The following is a description of a gene set: from publication Ramirez K, Chandler KJ, Spaulding C, Zandi S, Sigvardsson M, Graves BJ, Kee BL (PMID 22608498) Genes down-regulated in hematopoietic stem cells versus CD4 T cells. Expression profiling of Rag2-deficient Ets1++ and Rag2-deficient Ets1-- mature NK cells and WT bone marrow progenitors, WT T cells, and WT Pro B cells studied in species Homo sapiens Human Gene Set: GSE37301_HEMATOPOIETIC_STEM_CELL_VS_CD4_TCELL_DN, and this is the list of marker genes: TRMT9B, HHATL, RNF32, MCOLN2, MUTYH, IL18R1, IL16, SLC22A9, TBC1D16, ART5, BYSL, UQCC4, CD44, FOXB2, STN1, STMN4, DNTT, NKX6-3, MS4A10, OTUD6A, JPH2, ACSM4, KLRD1, KCNH4, PROSER2, KLHL41, CD177, CDH3, MPP3, PCDH12, BRSK2, IRX6, VGLL1, SCGN, RGL3, PIGA (NCBI Gene Id 5277), SIT1, MYH7, GALNT15, GZMA, PIK3R6, RERE, KCNH5, RGS12, ASB11, CDPF1, BAG3, SLC9C1 (solute carrier family 9 member C1), SYNDIG1, MPP1, BDNF, CAPN8, TSPYL5, MARCHF1, FZD4, IYD, AKAP14, SLC22A3, RNF225, FMOD, PHB2, TBC1D21, SLC30A10, SLC25A35, CD40, RRAD, ARSI, NAGS, CCDC160, TEAD2, RRAS, NCF1, PCDH7, MNS1, SCARF1, TSPAN17, DKK1, CHST7, EPSTI1, KCNJ16, IGSF23, CCR6 (NCBI Gene Id 1235), VWA5B2, SEMA3F, TMCO1, MZF1, LYPD3, PSMA7, TBC1D2, SNORD22, CPNE2, PELI3, FAM171A1, LY6S, MESP1 (mesoderm posterior bHLH transcription factor 1), RORB, PLAAT1, RTF2, MROH3P, POFUT2, ZFP92, LHPP, UBXN2B, NKAIN2, EVC, ARL5C, MRPS18B, SIDT1, TVP23B, FOXA3, GPRIN3, DISP3, GET1, TNS2, KCNG1, LRP12, HLA-B, PDE8A, DSTYK, UPK3BL1, PRG2, LYNX1, LARP1B, PDXK, P3H2, H2BC26, BCHE, PRF1, FAM221B, DMGDH, CSTA, PPY, SLC16A5, DCC, ABCC8, KCNN3, EXD1, PCSK1, ADAP1, CCN5, SLC22A13, KIFBP, COQ8B, SUGT1, SGSM2, LTBP1, RWDD1